The following is a description of a gene set: Neurologically relevant transcripts with highest variance accounted for by mouse strain (genotype) differences. Human Gene Set: CHESLER_BRAIN_HIGHEST_GENETIC_VARIANCE from publication Chesler EJ, Lu L, Shou S, Qu Y, Gu J, Wang J, Hsu HC, Mountz JD, Baldwin NE, Langston MA, Threadgill DW, Manly KF, Williams RW (PMID 15711545) species: Mus musculus Patterns of gene expression in the central nervous system are highly variable and heritable. This genetic variation among normal individuals leads to considerable structural, functional and behavioral differences. We devised a general approach to dissect genetic networks systematically across biological scale, from base pairs to behavior, using a reference population of recombinant inbred strains. We profiled gene expression using Affymetrix oligonucleotide arrays in the BXD recombinant inbred strains, for which we have extensive SNP and haplotype data. We integrated a complementary database comprising 25 years of legacy phenotypic data on these strains. Covariance among gene expression and pharmacological and behavioral traits is often highly significant, corroborates known functional relations and is often generated by common quantitative trait loci. We found that a small number of major-effect quantitative trait loci jointly modulated large sets of transcripts and classical neural phenotypes in patterns specific to each tissue. We developed new analytic and graph theoretical approaches to study shared genetic modulation of networks of traits using gene sets involved in neural synapse function as an example. We built these tools into an open web resource called WebQTL that can be used to test a broad array of hypotheses., and this is the list of marker genes: SC5D, ACAA1, PSTK, SNHG6, MEF2C, COL4A1, PRDX2, TOX4, RGS19, RPP14, PHLDA1, MAP1B, MYOC, CPSF2, SNHG11, BCAT2, C5orf34, VPS52, GNB1, IGHM, SCG5, MTIF2, CCL21, PTTG1, PAM, ACKR1, C4orf3, THUMPD1 (NCBI Gene Id 55623), KCNJ9, BCL2A1, ALAD, CAP1, HJURP, FOLH1, ALDH7A1, TULP3 (NCBI Gene Id 7289), OCEL1, PDXDC1